Given this list of marker genes RBX1, ASB9, SOCS2, KLHDC1, ASB11, SOCS7, ANKRD9, CUL5, ASB4, ARIH2, ELOB, RNF7, ELOC, PCMTD1, SPSB3, here is a description of the gene set: A ubiquitin ligase complex in which a cullin from the Cul5 subfamily and a RING domain protein form the catalytic core; substrate specificity is conferred by an elongin-BC adaptor and a SOCS/BC box protein. studied in species Homo sapiens Human Gene Set: GOCC_CUL5_RING_UBIQUITIN_LIGASE_COMPLEX